The following is a description of a gene set: species: Mus musculus The methylation of peptidyl-lysine to form either the mono-, di- or trimethylated derivative. Mouse Gene Set: GOBP_PEPTIDYL_LYSINE_METHYLATION, and this is the list of marker genes: Setd2, Kmt5a, Antkmt, Setd6, Mettl21c, Atpsckmt, Vcpkmt, Mettl18, Ehmt1, Eef1akmt3, Eef2kmt, Etfbkmt, Kmt2a, Wdr5, Setd7 (NCBI Gene Id 73251), Camkmt, Mettl21a (methyltransferase 21A, HSPA lysine), Smyd2, Ehmt2, Eef1akmt1, Eef1akmt2